The following is a description of a gene set: Binding to apolipoprotein A-I. Mouse Gene Set: GOMF_APOLIPOPROTEIN_A_I_BINDING studied in species Mus musculus, and this is the list of marker genes: Trem2, Lcat, Abca1, Hspd1, Scarb1